The following is a description of a gene set: studied in species Homo sapiens Human Gene Set: MIR3156_3P from publication Chen Y, Wang X (PMID 31504780) Genes predicted to be targets of miRBase v22 microRNA hsa-miR-3156-3p in miRDB v6.0 with MirTarget v4 prediction scores > 80 (high confidence targets)., and this is the list of marker genes: MYF6, MCC, IGF2BP1, YTHDF2, AGBL3, ELF2, ZNF732, HNF1B, CWH43, ZNF189, HLA-DPB1, ZNF763, ZNF124, NEXMIF, UBE3C, ACVR1C, BTF3L4, ERLIN1, ANKRD44, ABCA9, ZNF773, ZNF37A, MIS12, CENPP, PENK, POLR1B, MEIS1, C2orf49, VASH1, TCF20, CDC25A, ZNF230, ZNF14, UBASH3B, ZNF439, ZNF426, SEPTIN11, ZNF586, ZNF544, GRIA2, NR2C2, HSPA14, GCC1, FREM2, NUFIP2, HTRA4, CRKL, ZFP36L1, SLC31A1, KMT2A, USP48, NCAPG, INO80D, ZFP90, ZNF440, ATXN1, IKZF2, ZFAND2A, RFX3, CNDP2, MEF2C, ISL1, LAMC2, UBE2W, ZNF302 (zinc finger protein 302), ACP2, TARDBP, SMARCA1, MDM4 (NCBI Gene Id 4194), TPT1, ZNF594, CAPRIN2, ZNF559-ZNF177, TNPO1, ZNF384, CTSC, ZNF559, ZNF367, ZNF584, ZNF268, GPR63, SPRTN, TPK1, ZNF135, PCDH15 (protocadherin related 15), ZNF781, UBQLN1, ZNF146, SMAP2